Given this list of marker genes DLX1, SOX8, NOTCH1, SOX9, DLX2, RAB37, CNTF, here is a description of the gene set: studied in species Homo sapiens Human Gene Set: GOBP_REGULATION_OF_PHOTORECEPTOR_CELL_DIFFERENTIATION Any process that modulates the frequency, rate or extent of photoreceptor cell differentiation. An example of this process is found in Drosophila melanogaster.